Given this list of marker genes KARS1, CST3, VDAC3, RPS19, PLTP, CYBA, ISCU, ARPC2, HLA-F, TMX1, RHOA, HLA-DPB1, PRCP, TSPO, COX4I1, HLA-A, SSR4, here is a description of the gene set: Genes down-regulated during transition from L0 (non-tumor, not infected with HCV) to L1 (non-tumor, infected with HCV) in the development of hepatocellular carcinoma. species: Homo sapiens Human Gene Set: IIZUKA_LIVER_CANCER_PROGRESSION_L0_L1_DN from publication Iizuka N, Oka M, Yamada-Okabe H, Mori N, Tamesa T, Okada T, Takemoto N, Sakamoto K, Hamada K, Ishitsuka H, Miyamoto T, Uchimura S, Hamamoto Y (PMID 15710396) Using high-density oligonucleotide array, we comprehensively analyzed expression levels of genes in 50 hepatocellular carcinoma (HCC) samples with positive hepatitis C virus (HCV) serology (well (G1), moderately (G2), and poorly (G3) differentiated tumors) and 11 non-tumorous livers (L1 and L0) with and without HCV infection. We searched for discriminatory genes of transition (L0 vs. L1, L1 vs. G1, G1 vs. G2, G2 vs. G3) with a supervised learning method, and then arranged the samples by self-organizing map (SOM) with the discriminatory gene sets. The SOM arranged the five clusters on a unique sigmoidal curve in the order L0, L1, G1, G2, and G3. The sample arrangement reproduced development-related features of HCC such as p53 abnormality. Strikingly, G2 tumors without venous invasion were located closer to the G1 cluster, and most G2 tumors with venous invasion were located closer to the G3 cluster (P=0.001 by Fisher's exact test). Our present profiling data will serve as a framework to understand the relation between the development and dedifferentiation of HCC.